The following is a description of a gene set: The proliferation of cells in the inner cell mass. Mouse Gene Set: GOBP_INNER_CELL_MASS_CELL_PROLIFERATION studied in species Mus musculus, and this is the list of marker genes: Ncapg2, Cops2, Zpr1, Gins4, Dmbt1, Brca2, Setdb1, Brd4, Gins1, Chek1, Taf8, Ndel1, Sall4, Palb2, Ints1, Sbds, Pelo